Given this list of marker genes Rpl27, Rps11, Rps6, Rps2, Rps25, Rpl26, Rpl3, Rpl18, Rpl6, Rpl37, Rpl4, Gspt2, Rps26, Rps28, Rpl24, Rps18, Rpl14, Rpl9, Rpl15, Rplp2, Rpl23a, Rpl12, Rps4x, Rps10, Rpl11, Rpl38, Rpl39, Rps27l, Rpl39l, Ubb, Pabpc1, Rps8, Rps7, Rpl37a, Rps13, Rps24, Rps20 (ribosomal protein S20), Rpl19, Rps15, Rpl3l, Rps12, Rpl7, Rps23, Rpl29, Rpl18a, Rpl27a, Rpl36a, Rps5, Rps9, Rpl36al, Rpl13, Rps17, Rpl37rt, Rps3a1, Fau, Rps19, here is a description of the gene set: part of: Nonsense-Mediated Decay (NMD) electronically inferred by orthology from the curated human pathway studied in species Mus musculus This event has been computationally inferred from an event that has been demonstrated in another species.<p>The inference is based on the homology mapping from PANTHER. Briefly, reactions for which all involved PhysicalEntities (in input, output and catalyst) have a mapped orthologue/paralogue (for complexes at least 75% of components must have a mapping) are inferred to the other species. Reactome Pathway: Nonsense Mediated Decay (NMD) independent of the Exon Junction Complex (EJC)